Given this list of marker genes Krtap19-5, Rph3al, Bcas1, Nrxn1, Sell, Pllp, Xkrx, Plp1, Arsb, Slc26a5, Aicda, Pdp2, Fuca1, Tspan6, Adi1, Cpsf7, Slc6a6, Otub2, Phlpp1, Slc22a21, Cngb1, Lcmt2, Nudt15, Gstm7, Gucy1a2 (guanylate cyclase 1, soluble, alpha 2), Zmpste24, Plcd3, here is a description of the gene set: Genes predicted to be targets of miRBase v22 microRNA mmu_miR_7233_5p in miRDB v6.0 with MirTarget v4 prediction scores > 80 (high confidence targets). from publication Chen Y, Wang X (PMID 31504780) Mouse Gene Set: MIR_7233_5P studied in species Mus musculus